Given this list of marker genes PIN1, PPIL1, PPIA, P4HB, EGLN2, NTMT1, OGFOD1, P3H2, here is a description of the gene set: studied in species Homo sapiens Human Gene Set: GOBP_PEPTIDYL_PROLINE_MODIFICATION The modification of peptidyl-proline.